Given this list of marker genes DNAJC21, SLC2A2, SLC25A13, MYO5B, TALDO1, ABCB4, DZIP1L, SLC51B, SBDS, AKR1D1, ABCB11, TJP2, KIF12, PKHD1, MPV17 (mitochondrial inner membrane protein MPV17), SLC10A1, VPS50 (NCBI Gene Id 79604), UNC45A, AP1B1, ABCD3, CCDC47, SEMA7A, NR1H4 (nuclear receptor subfamily 1 group H member 4), ATP8B1, VPS33B, AMACR (NCBI Gene Id 23600), EFL1, here is a description of the gene set: Abnormal serum bile acid concentration Human Gene Set: HP_ABNORMAL_SERUM_BILE_ACID_CONCENTRATION studied in species Homo sapiens A deviation from the normal concentration of serum bile acid concentration.